Given this list of marker genes Pitx1, Epas1 (NCBI Gene Id 13819), Myod1, Itgb1, Tcf7l2, here is a description of the gene set: The process in which the developmental fate of a cell becomes restricted such that it will develop into a myoblast. A myoblast is a mononucleate cell type that, by fusion with other myoblasts, gives rise to the myotubes that eventually develop into skeletal muscle fibers. Mouse Gene Set: GOBP_MYOBLAST_FATE_COMMITMENT species: Mus musculus